Given this list of marker genes RBL1, GRK4, TUBGCP4, RAD51AP1 (RAD51 associated protein 1), TBC1D4, SMC4, EPC2, TNKS1BP1, SEPTIN10, KLRC1, TWF2, NAGA, RNASET2, AMER1, RNASE4, ALS2 (alsin Rho guanine nucleotide exchange factor ALS2), ABCA1, ZUP1, CTSF, BLK, SGK1, SCN10A, ACSF2 (acyl-CoA synthetase family member 2), SLC17A9, MINDY2, PDK4, ZBTB42, SNX14, ODR4, RBP4, CTSW, SEC11A, PARVA, AHRR, PRR5L, C4orf46, NTN5, MED14, IRF2BPL, MYADM, CUZD1, PABPC1L, RAB11FIP2, MRPL10, TMEM30A-DT, GTPBP2, ACOT13, KLRD1 (killer cell lectin like receptor D1), MGST2 (microsomal glutathione S-transferase 2), FAM110C, VWA5A, PARP14 (NCBI Gene Id 54625), CCDC89 (coiled-coil domain containing 89), SYT7, TLR7, EPS8L2, B4GALT3, CERK, MAP4K4, EPB41L2, HLA-G, CREB3, B3GNT8, NOX4, SIAE, NR1D2, ABCG1, DNMBP, KLHL30, FOXK1, NLGN3, JMJD1C, FHIP2A, PDLIM5, NTAQ1, THADA, FEN1, ZNF622, TNRC6B, FCHO1, AP3D1, PHYHD1, RCAN3, TAMALIN, NIN, AP1S2, KATNBL1 (NCBI Gene Id 91186), NISCH, DENND2B, STON1, TMEM31, CARHSP1, PLSCR4, MPEG1, ADAMTSL2, ANKRD6, ATP1A2 (NCBI Gene Id 93186), SLC9A5, ACVR1B, CATSPERZ, ACSBG1, NRARP, RBM7, KCNK6, ABLIM1, ACVR2A, RASGRP2, RHOF, CNOT11, TBL1XR1, CGGBP1, NDRG4 (NDRG family member 4), GNG2, ADRA2C, SEPTIN12, TP53BP2, SETD7, PSMB11, IL18BP, BMI1, MIEN1, SEMA6D, SNORD89, PIK3C2A (NCBI Gene Id 5286), SUSD4, THAP6, AKIRIN1, RECK, B3GNT5, GM2A, WAPL, KCTD14, TANGO2, IFI44, SS18, ANKRD44, CNTN6, SLC43A2, CNST, TTC27, EDEM3, DSTN, CD163, MKRN3, FUT10, CNDP2, NLRC5, NCMAP, TCP11, SMAD6, STAT5A, TSPAN14, PDE4A, ABTB1, SNX13, PRDM2, SYP (NCBI Gene Id 6855), RNF149, PRG4, CD99L2, CX3CL1, AKAP13, GNAI3, TMPRSS11D, UGT2B4, FBXL3, RPS6KL1, SMG1, CLBA1, B3GALT2, CDK19, RORA, STAT1 (signal transducer and activator of transcription 1), HLA-DOB, ST7L, SH2D1B, MGAT4A, RPL17, RIMOC1, CNDP1, HERC3, PTPRJ, TTC39B, NIPAL3, ST8SIA4 (ST8 alpha-N-acetyl-neuraminide alpha-2,8-sialyltransferase 4), MBNL3, TAP1, SARAF, TBXA2R (thromboxane A2 receptor), VPS28, ZDHHC20, AOPEP, SH3GLB2, FGF13, ITGB2 (NCBI Gene Id 3689), DZANK1, TGFBR2, GLB1L3, MACC1, ACOX1, here is a description of the gene set: species: Homo sapiens from publication Liu PT, Stenger S, Li H, Wenzel L, Tan BH, Krutzik SR, Ochoa MT, Schauber J, Wu K, Meinken C, Kamen DL, Wagner M, Bals R, Steinmeyer A, Zügel U, Gallo RL, Eisenberg D, Hewison M, Hollis BW, Adams JS, Bloom BR, Modlin RL (PMID 16497887) In innate immune responses, activation of Toll-like receptors (TLRs) triggers direct antimicrobial activity against intracellular bacteria, which in murine, but not human, monocytes and macrophages is mediated principally by nitric oxide. We report here that TLR activation of human macrophages up-regulated expression of the vitamin D receptor and the vitamin D-1-hydroxylase genes, leading to induction of the antimicrobial peptide cathelicidin and killing of intracellular Mycobacterium tuberculosis. We also observed that sera from African-American individuals, known to have increased susceptibility to tuberculosis, had low 25-hydroxyvitamin D and were inefficient in supporting cathelicidin messenger RNA induction. These data support a link between TLRs and vitamin D-mediated innate immunity and suggest that differences in ability of human populations to produce vitamin D may contribute to susceptibility to microbial infection. Human Gene Set: GSE8921_UNSTIM_0H_VS_TLR1_2_STIM_MONOCYTE_6H_DN Genes down-regulated in monocytes: untreated versus M. tuberculosis 19 kDa lipopeptide (6h).